Given this list of marker genes GAL, NPRL2, DEPDC5 (NCBI Gene Id 9681), LGI1, MICAL1, RELN, NPRL3, here is a description of the gene set: species: Homo sapiens Focal cognitive seizure Human Gene Set: HP_FOCAL_COGNITIVE_SEIZURE A focal cognitive seizure involves an alteration in a cognitive function (which can be a deficit or a positive phenomenon such as forced thought), which occurs at seizure onset. To be classified as a focal cognitive seizure, the change in cognitive function should be specific and out of proportion to other relatively unimpaired aspects of cognition, because all cognition is impaired in a focal impaired awareness seizure.